The following is a description of a gene set: species: Homo sapiens Any process that modulates the occurrence or rate of cell death by apoptotic process in hippocampal neurons. Human Gene Set: GOBP_REGULATION_OF_HIPPOCAMPAL_NEURON_APOPTOTIC_PROCESS, and this is the list of marker genes: CX3CL1, STAMBP (NCBI Gene Id 10617), LCN2, DRAXIN, TREM2, CX3CR1